The following is a description of a gene set: from publication Abbud RA, Kelleher R, Melmed S (PMID 14576184) Mouse Gene Set: ABBUD_LIF_SIGNALING_1_UP Leukemia inhibitory factor (LIF) mediates the hypothalamo-pituitary-adrenal stress response. Transgenic mice overexpressing LIF in the developing pituitary have altered pituitary differentiation with expansion of corticotropes, maintenance of Rathke's cleft cysts, and suppression of all other pituitary cell types. Affymetrix GeneChips were used to identify modulators of LIF effects in corticotrope (AtT-20) and somatolactotrope (GH(3)) cells. In addition to genes known to respond to LIF in corticotrope cells, corticotrope-specific changes were also observed for genes involved in glycolysis and gluconeogenesis, transcription factors, signaling molecules, and expressed sequence tags. Two transcription factors identified, CCAAT/enhancer-binding protein beta (C/EBPbeta) and glial cell-derived neurotrophic factor (GDNF)-inducible factor (GIF), dose-dependently induced expression of the rat POMC promoter when overexpressed in AtT-20 cells. LIF further induced POMC transcription with C/EBPbeta, but not with GIF. C/EBPbeta also induced expression of the SOCS-3 promoter that was further enhanced by cotreatment with LIF. However, GIF did not affect SOCS-3 expression. These results indicate that C/EBPbeta and GIF are downstream effectors of LIF corticotrope action. LIF also stimulates the expression of inhibitors of its actions, such as SOCS-3 and SH2 domain-containing tyrosine phosphatase-1. alpha(2)-HS-glycoprotein (AHSG)/fetuin, a secreted protein that antagonizes bone TGFbeta/bone morphogenic protein signaling, was induced by LIF in a signal transducer and activator of transcription-3-dependent fashion. Pretreatment with AHSG/fetuin blocked LIF-induced expression of the POMC promoter independently of SOCS-3. Thus, using GeneChips, C/EBPbeta and GIF have been identified as novel mediators and AHSG/fetuin as an inhibitor of LIF action in corticotropes. species: Mus musculus Genes up-regulated in AtT20 cells (pituitary cancer) after treatment with LIF., and this is the list of marker genes: Lrg1, Socs3, Rgs4, Cxcl14, Upp1, Kng1, Fgg, Anxa8, Xbp1, Nmi, Tmem176b, Lbp, Aldoc, Gpx3, Vwf, Ptpn1, Tmem176a, Il1r1, Cyb561, Irf1, Sqor, Lcn2, Sct, Stat3, Tnfrsf1a, Acaa2, Tspan4, Has1, Psmb8, Man1a, Rasa3, Cebpb, Tapbp, Bcl3, Rhou, Gramd2b, Klf10, Fbp1 (NCBI Gene Id 14122), Gpcpd1, Mpo, Rnase2b, Elf3, St3gal1